Given this list of marker genes Mir3069, Gscdt, A630072L19Rik, Serpina3l-ps, Serpina10, Tc2n, Asb2, Serpina3n, Gm19238, Gm2614, Eml5, Gm46376, Fam181a, Gm40552, Spata7, Serpina3h, Gm25486, Syne3, Rps6ka5, Kcnk10, Gm25801, Tcl1, Gpr65, Gon7, Ifi27l2b (interferon, alpha-inducible protein 27 like 2B), Flrt2, Psmc1, Atg2b, Gm10432, Serpina6, Gm17198, Slc24a4, Gm6869 (NCBI Gene Id 633945), Calm1, Ttc8, Serpina1b, Gm18848, Gm20604, Efcab11, Serpina1f, 4930408O17Rik, Serpina3b, 9330161L09Rik, Gsc, Cpsf2, Bdkrb2, Catsperb, Lgmn, Tcl1b1, Tcl1b2, Rpl30-ps8, Snhg10, 4930556H04Rik, Gm10433, Gm5656, Prima1, Mir1936, Ttc7b, Serpina3e-ps, Rpl17-ps2, Gm47415, Serpina16, 4930474N09Rik, Gm8482, D230049E03Rik, Papola, Gm19951, Gm19554, Gm40893, Gpr68, Serpina1d, Serpina3d-ps, Trip11, A930040O22Rik, 9530050K03Rik, Ndufb1 (NCBI Gene Id 102631912), Mylf-ps, Gm17043, Foxn3, Otub2, Serpina12, Kcnk13, Mir1190, Dicer1, Ifi27, Ifi27l2a, Gm30198, Bdkrb1, Ak7, 9430031K09Rik, Gm47639 (NCBI Gene Id 118568009), Gm35412, Gm6863, Gm8893, Vrk1, Fbln5, Gm2398, Gm2721, Serpina3f, Kif4-ps, B430119L08Rik, Glrx5, Ccdc88c, Gm26839, Ptpn21, Tunar, Rin3, Serpina3i, Serpina5 (NCBI Gene Id 268591), Tcl1b3, 3300002A11Rik, Ubr7, Tdp1, Gm36756, Gm6918, Moap1, Gm5186, Gm35326, Serpina3c, Serpina1c, Gm15523, Gm24334, Zc3h14, Ppp4r4, Gm20036, D130020L05Rik, 5330409N07Rik, Btbd7 (NCBI Gene Id 70608), Ppp4r3a, Gm19898, Gm8895 (predicted gene 8895), Gm8785, Cox8c, Gm25203, Chga, Gm40557, Gm18501, Serpina4-ps1, Gm29508, Serpina3j, Gm7143, Golga5, Serpina1e, Dglucy, Nrde2, Unc79, 4930477G07Rik, Clmn, Gm21056, Gm8918, Ddx24, Gm18795, Gskip, Itpk1, Gm35274, Gm17042, Serpina3k, Tcl1b5, Tcl1b4, Serpina3m, Serpina3g, Lyset, Atxn3, Gm20069, Serpina11, D430019H16Rik, AU015791, Galc, Serpina3a, 1700064M15Rik, Serpina9, Serpina1a, here is a description of the gene set: Mouse Gene Set: chr12E studied in species Mus musculus